The following is a description of a gene set: studied in species Mus musculus Mouse Gene Set: GOBP_FATTY_ACID_HOMEOSTASIS Any process involved in the maintenance of an internal steady state of fatty acid within an organism or cell., and this is the list of marker genes: Prkaa1, Got1, Ins1, Pold1, Enpp7, Prkaa2, Apoe, Dgat2, Sirt1, Abcd1, Ins2 (insulin II), Xbp1, Dgat1, Adora1 (NCBI Gene Id 98749), Gpam, Nr1h4, Mlxipl